Given this list of marker genes MEFV, IRAK3, ACP5, JAK3, CCR7, SLAMF1, TIGIT, MIR21 (NCBI Gene Id 406991), PIBF1, LILRB1, NFKB1, ARRB2, TLR8, C1QBP, IL10, LILRA5, CMKLR1, THBS1, here is a description of the gene set: Human Gene Set: GOBP_NEGATIVE_REGULATION_OF_INTERLEUKIN_12_PRODUCTION Any process that stops, prevents, or reduces the frequency, rate, or extent of interleukin-12 production. species: Homo sapiens